The following is a description of a gene set: studied in species Homo sapiens Human Gene Set: GOBP_CORONARY_ARTERY_MORPHOGENESIS The process in which the anatomical structures of coronary arteries are generated and organized. Coronary arteries are blood vessels that transport blood to the heart muscle., and this is the list of marker genes: NRP1, HAND2, SEC24B, ARID2, LRP2, VEGFA, TBX1, TGFBR1, NOTCH1